The following is a description of a gene set: Any process that modulates the frequency, rate or extent of collagen fibril organization. Mouse Gene Set: GOBP_REGULATION_OF_COLLAGEN_FIBRIL_ORGANIZATION studied in species Mus musculus, and this is the list of marker genes: Rb1, Tnxb, Colgalt1, Col6a1, Chadl, Aebp1, Emilin1, Efemp2